The following is a description of a gene set: studied in species Homo sapiens Human Gene Set: GOBP_PROTEIN_LOCALIZATION_TO_EXTRACELLULAR_REGION Any process in which a protein is transported from one specific location in the extracellular region to another, or maintained in a specific extracellular location., and this is the list of marker genes: SERP1, RAC1, ADORA2A, NEUROD1, C1QTNF12, HNF1A, TRH, GNAI1, PHPT1, FFAR2, NLGN2, SLC4A8, GNAO1, PRKCB, HNF4A, SLC25A22, NRROS, OPRM1, RAB3A, GIP, PICK1, SNCG, TARDBP, G6PC2, MIR146A, RSAD2, RAB11FIP5, GPR27, MIR29B1, RHBDF2, HADH, ADCY5, C2CD2L, TVP23B, LMF1, SYT7, MYO18A, SLC2A2, ZBED6, CTAGE1, SUCNR1, GNAS, HLA-DRB1, CFTR, IL12B, PPY, SERGEF, IER3IP1, ABCA1, ENSA, PPP3CB, DRD3, SREBF1, SLC8B1, NBL1, MIR19A, PTPN11, NOS2, INS, CBLN4, F2RL1, CASR, MICOS10-NBL1, SIRT6, SRI, VGF, STXBP4, BLOC1S3, PORCN, RFX6, LRRC8A, ADRA2C, NR1H3 (NCBI Gene Id 113429), MIR93, HNF1B, C1QTNF3, RPH3AL, IL13, ACSL4, ANG, TUNAR, ACVR2B, TANGO2, CD38, VIP, ARL4D, PAFAH1B1, ADTRP, MTNR1B, MC4R, CAVIN1 (caveolae associated protein 1), RHBDF1, CTAGE6, TMED2, BAD, RAB27A, SOX4, GNA11, FAM3D, SIRT3, PFKL, MIR199A1, MPC2, PRKCA, NECAB3, SYTL4, PLA2G1B, ARF6, SIDT2, LRRC32, CER1, CCN3, ADRA2A, NMU, F2R (NCBI Gene Id 2149), GNAZ, PRKAR1A, RAPGEF4, GOLPH3L, GCK, AP1M2, MIDN, GPR68, VPS13A, KCNA5, AP1B1, ADCYAP1, PLCB1, ADAM8, PRKCE, CWH43, FRMD4A, SIRT4, AP1G1, ATP13A2, PFKM, EXPH5, NAGPA, TGFB1, KCNJ8, CD200, MYRIP, COMT, NR1H4, IGF1, MCU, ITPR1, RAP1GDS1, CPLX1, FOXA2, FAM3A, BSG, KCNN4, MAFA, CPT1A, DRD2, UCP2, MIA3, PTPN23, AFM, LTBP2, GHRL, ANO1, DNM1L, RAPGEF3, MON1A, TANGO6, CTAGE15, SLC9B2, CLTRN, VSNL1, INHBB, CAPN10, CD33, PCSK5, BMAL1, BAIAP3, IRS1, EDNRB, NR1H2, TMED10, PCK2, TCIRG1, LEP, CTAGE8, IDH2, SLC12A2, SLC16A1, NR1D1, ORAI1, FGA, GPER1, PRKACA, GOLPH3, ADAM9, ABCG1, DOC2B, CLSTN3, TREM2, SEL1L, PFKFB2, NPFF, GPLD1, VPS35, ARFGAP3, NDUFAF2, ACHE, LRP5, SYBU, BRSK2 (BR serine/threonine kinase 2), BMP8A, APOE, KCNB1, CELA2A, STXBP3, UNC13B, C1QTNF5, PLA2G6, OXCT1, DPH3, HCAR2, ABCC8, VEGFC, DRD4 (NCBI Gene Id 1815), BLOC1S6, CLOCK, CAMK2G, GNPTAB, CCL5, CD2AP, PPIA, CRH, SLC30A8, DAND5, NR0B2, EFNA5, TFAP2B, ALOX5, SNAP25, HMGCR, EPHA5, TRPA1, RCN3, F2, SVBP, RBM4, TTN, ILDR2, AP1S1, TMEM132A, FUT11, HPS6, GSDMD, ABCA12, RIMS2 (NCBI Gene Id 9699), ANKRD1, UCN3, CCDC186, GHSR, P3H1, FGB, BMP6, TRPM5, OR51E2, WLS, SSTR5, FBN1, ERP29, CYB5R4, CTAGE9, MYH10, OLFM2 (NCBI Gene Id 93145), MIR199B, RAB11FIP3, ACVR1C, TGFB3, GAL, FGG, NEO1, IRS2, PSMD9, RAB11FIP2, IL1A, SMAD2, APBB1, HIF1A, DNAJC1, BLK, STX1A, COPG2, GPRC6A, IL1RN, PARD6A, REST, TNF, KRT20, KLF7, PARK7, STX4, JAK2 (NCBI Gene Id 3717), FOXO1, MIR766, TCF7L2, FKBP1B, PPARD, B3GLCT (beta 3-glucosyltransferase), SYT4, JAGN1, PTPRN2, GIPR, PDE8B, MLXIPL, CANX, OSBP, PPID, PTPRN, PRF1, RHBDD3, ADCY8, TGFB2, UQCC2, FBN2, MIR30C1, TACR2, ENY2, STEAP3, RAF1, PPARG, FFAR1, NKX6-1, KCNJ11, ABAT, TLR2, GJA5, IL12A, TRPM4, PLEK, SNX19, F2RL2, GLUD1, TVP23C, SELENOT, TM7SF3, LTBP1, PIM3, PER2, NADK, TLR4, CDK16, RAB11FIP1, CYP51A1, MTTP, MIA2, SAA1, NNAT (NCBI Gene Id 4826), SEC24A (NCBI Gene Id 10802), M6PR (mannose-6-phosphate receptor, cation dependent, NCBI Gene Id 4074), GCG, TMEM167A, SCG2, CBLN1, PCLO, FUT10, IL6, MYOM1, MIR19B1, RFX3, GPR119, TVP23A, PRKN, DYNLL1, COPG1, ISL1, CHRM3, ARFIP1, FAM3B (FAM3 metabolism regulating signaling molecule B), RBP4, CPLX3, UBE2Q1, CTAGE4 (CTAGE family member 4), CHGA, P2RX7, CARTPT, COMP, APBB3, PDX1, RAB11B, AACS, PDIA4, EIPR1, IL1B (NCBI Gene Id 3553), IFNG, KCNK16